The following is a description of a gene set: studied in species Mus musculus Wnt signaling pathway and pluripotency Mouse Gene Set: WP_WNT_SIGNALING_PATHWAY_AND_PLURIPOTENCY, and this is the list of marker genes: Ppp2cb, Wnt5b, Gsk3b, Ctnnb1 (catenin beta 1), Ctnnd1, Myc, Lef1, Ptpa, Ppp2r2d, Wnt10b, Wnt4, Fzd5, Jun, Hnf1b, Fzd8, Dvl2, Fosl1, Apc, Mapk9 (NCBI Gene Id 26420), Wnt16, Ctbp1, Wnt3a, Ccnd1, Ppm1j, Fzd1, Hnf1a, Axin2, Ccnd2, Wnt3, Wnt11, Dvl3, Ppp2ca (protein phosphatase 2 (formerly 2A), catalytic subunit, alpha isoform), Prkcd, Dvl1, Wnt7a, Mmp7, Ldlr, Nanog, Plau, Wnt7b, Prkcg (protein kinase C, gamma), Prkca, Trp53, Wnt1, Nfya, Prkci, Ctbp2, Ppp2r1b, Crebbp, Prkce, Frat1, Mapk10, Fzd4, Fzd6, Wnt2, Fbxw2, Sox2, Tcf7l1, Prkch, Tcf4, Fzd3, Pou5f1, Nlk, Ppp2r2a, Zbtb33, Racgap1, Fzd2, Map3k7, Cd44, Axin1, Ppp2r5c, Prkcb, Fzd9, Lrp6, Ppp2r2b (NCBI Gene Id 72930), Nkd1, Csnk1e, Wnt10a, Ep300, Ppp2r2c, Nkd2, Rhoa, Prkcz, Ppard, Fzd7, Prkd1, Pafah1b1, Ppp2r1a, Ccnd3, Prkcq, Wnt9b, Ppp2r5e, Lrp5, Foxd3, Wnt2b, Wnt5a, Wnt6 (wingless-type MMTV integration site family, member 6)